The following is a description of a gene set: Neuronal activity regulates the development and maturation of excitatory and inhibitory synapses in the mammalian brain. Several recent studies have identified signalling networks within neurons that control excitatory synapse development. However, less is known about the molecular mechanisms that regulate the activity-dependent development of GABA (gamma-aminobutyric acid)-releasing inhibitory synapses. Here we report the identification of a transcription factor, Npas4, that plays a role in the development of inhibitory synapses by regulating the expression of activity-dependent genes, which in turn control the number of GABA-releasing synapses that form on excitatory neurons. These findings demonstrate that the activity-dependent gene program regulates inhibitory synapse development, and suggest a new role for this program in controlling the homeostatic balance between synaptic excitation and inhibition. from publication Lin Y, Bloodgood BL, Hauser JL, Lapan AD, Koon AC, Kim TK, Hu LS, Malik AN, Greenberg ME (PMID 18815592) Human Gene Set: LIN_NPAS4_TARGETS_UP Genes up-regulated in neurons after NPAS4 knockdown by RNAi. studied in species Mus musculus, and this is the list of marker genes: DDHD2, TSTD3, PTP4A1, MLLT3, SEC61A1 (NCBI Gene Id 83289), PNMA2, IMPA1, RAB2B, HS2ST1, MOK, PFKFB4, PTPA, TTYH1, RASGRF2, RCAN1, RBM34, SLC8A1, GABRB2, CHMP2B, KIF3B (kinesin family member 3B), SPOCK2, PPP1R3E, SPRYD7, PRKAA2, AHI1, STXBP5, PEX14, MFSD6, MSI1, RNF182, TMEM74, SLC27A4, ADD2, DNAJC27, VPS26C (NCBI Gene Id 10311), ARHGAP20 (NCBI Gene Id 57569), SEPHS2, C3orf70, EPS15 (epidermal growth factor receptor pathway substrate 15), MLLT1, MATCAP1, C2orf69, SGK1, RNF152, USF1, NUP155, NRSN1, NTRK3, SAMD12, ATP2C1, HLA-B, SLC35A1, RRN3, ACTR10, CEP15, PCDH17, NEDD4L (NEDD4 like E3 ubiquitin protein ligase), XKR6 (NCBI Gene Id 83654, XK related 6), SOAT1, HSDL1, AP4E1, BSDC1, FAM107B, AKT3, PANX1 (pannexin 1), CAPN7, CLMP, MTFP1, DMAC2L, LNPEP, CHODL, VCPIP1, FAM8A1, SMUG1, CDKN1B, MRAS, FAM81A, TMEM267 (transmembrane protein 267), LBHD1, TMEM8B, CHMP7 (NCBI Gene Id 91782), SLC9A9, RBBP6, GABRB1, GINM1, FBXO8, FAM234A, CDC42SE2, TRIM67, GRIA3, MPP3, SNAP47, MARCHF9, AGO2, ASB1, RPL39L, LYPD6, NANS, CCT7, AP2B1, EPAS1, MYCL, CELF6, NELFB, ITPK1, RBM4, ST6GAL1, LRSAM1, NAA15, TBCK, GRAMD4, CCNG1, ZDHHC7, LRRC3 (NCBI Gene Id 81543), GMPS, PPP1R11, TDG, LPL, IFT43, KIAA0319, KIF26B, PNPLA6, CDK14, SMIM14, KCNK9, FAM32A, GPRIN2, MKRN3, CFAP97, BZW2, ABCF1, LPGAT1, CFAP418, DHX40, ZBTB6, HSPA1A, PLCXD3, ARHGEF7, RPS6KA3, RAB3B, B4GALT3, TIGAR, FAM210A, CAMSAP1, MTX3, B3GALNT1, DHCR24, FXYD6, ALDH1L2, ACOT7, MB21D2, MARCHF8, OGFRL1, PKIA, GMCL1, TMED8, SLF1, POMK, SERBP1, SCN3A, GNPDA1, PCSK2, PRKAB2, CDC42EP2, NIP7, SLC24A3, CHMP4B, DARS1, AK4, LRFN1